Given this list of marker genes ARID2, ARRB1, R3HDM1, IGFBP4, ECM1, CDKL5, CLEC12A, FNBP4, FHIP1B, RAB11FIP1, SOCS3, ZNRF1, RORA, GTF2IRD2, ETV3, VAX2 (ventral anterior homeobox 2), GABBR1, MGLL, ZMYM2, IL17A, SAA2, ZNF318, SMOX, CORO2A, TCP11L1, TREML2, ADARB1, TAGAP, KAT6B, CERK, RRAS2, LCORL, CLK1, RAMP1, CMTM6, KLHL3, ALS2CL, RBL2, IL17RC, CLIP2, ITGA5, PGM2L1, ARHGEF12, SATB1, MYO10, HS6ST1, ST6GALNAC3, INSR, IL1RL2, TRPM6, ZHX3, MYO9A, DGKG, NXPE3, ACP3, PRKCB, ACSBG1, NEDD4L, ST8SIA1, LCN8, CYSLTR2, IL6R, PDE3B, ARHGAP5, B4GALT4, TSC22D1, SIPA1L2, RORC, SEC22A, PLCB4, ABHD15, USP6NL, SCAI, DCAF6, PRRG1, ATP10D, EXOC6B, CCDC102A, PARP8, KIF1B, LTB, KLHL6, IFNGR2, ZHX2, KIF13A, VPS13C, XKRX, RIPK3, PLEKHF1, MITF, NEBL, JAML, NR1I3, LPAR6, MALT1, PPP1R3F, IL23R, CDH5, HERC3 (NCBI Gene Id 9838), BIK, PTPRZ1, CAMSAP2, CD302, TMEM176B, USP32, DISP1, CPM, TAF4B, XYLT2, NT5E, PAN3, DPY19L3, IL1R1, ARHGAP31, PRICKLE3, SEMA4F, IGFLR1, SLC12A7, EML5, TMIGD1, DST, OGT, IL17RE, TEX2, CCDC63, ZBTB20, RFLNB, SLC7A8, CARD6, TTYH3, NTRK3, NR1D2, RPRD1A, ZDHHC8, TMEM176A, TACSTD2, BTG1, BMAL1, TXK, AEBP2, TDRKH, TANC1, TRIB2, FAM20A, ELANE, RAB6B, TGM2, UPP1, FSD1L, PBXIP1, CASTOR2, WWP1, TBXA2R, RAB3GAP1, TUFT1, APPL2, SESTD1, SCP2, CD28 (NCBI Gene Id 940), KIF5C, SPEF2, CD72, IL2RA, LRIG1, DDX60, EMB, SGMS1, ADGRG3, GPR183, ZC3H12C, TBC1D30, KLF7, GGT5, LYSMD2 (NCBI Gene Id 256586), SFMBT2, BTG2, RGS10, RAB4A, DDX5, here is a description of the gene set: Genes down-regulated in fibroblasts: untreated versus IFNG. studied in species Homo sapiens IFNs are highly pleiotropic cytokines also endowed with marked anti-angiogenic activity. In this study, the mRNA expression profiles of endothelial cells (EC) exposed in vitro to IFN-alpha, IFN-beta, or IFN-gamma were determined. We found that in HUVEC as well as in other EC types genes were upregulated (>2-fold increase) by IFNs, including genes involved in the host response to RNA viruses, inflammation, and apoptosis. Interestingly, genes showed a >5-fold higher induction by IFN-alpha in EC compared to human fibroblasts; among them, the gene encoding the angiostatic chemokine CXCL11 was selectively induced by IFN-alpha in EC along with other genes associated with angiogenesis regulation, including CXCL10, TRAIL, and guanylate binding protein 1 (GBP-1). These transcriptional changes were confirmed and extended by quantitative PCR analysis and ELISA; whereas IFN-alpha and IFN-beta exerted virtually identical effects on transcriptome modulation, a differential gene regulation by type I and type II IFN emerged, especially as far as quantitative aspects were concerned. In vivo, IFN-alpha-producing tumors over-expressed murine CXCL10-11, GBP-1 and TRAIL, with evidence of CXCL11 production by tumor-associated EC. Overall, these findings improve our understanding of the anti-angiogenic effects of IFNs by showing that these cytokines trigger an anti-angiogenic transcriptional program in EC. Moreover, we suggest that quantitative differences in the magnitude of the transcriptional activation of IFNresponsive genes could form the basis for cell-specific transcriptional signatures. from publication Indraccolo S, Pfeffer U, Minuzzo S, Esposito G, Roni V, Mandruzzato S, Ferrari N, Anfosso L, Dell'Eva R, Noonan DM, Chieco-Bianchi L, Albini A, Amadori A (PMID 17202376) Human Gene Set: GSE3920_UNTREATED_VS_IFNG_TREATED_FIBROBLAST_DN